The following is a description of a gene set: studied in species Homo sapiens The process that mediates signaling interactions between one cell and another cell by transfer of current between their adjacent cytoplasms via intercellular protein channels and contributes to the process of cardiac conduction. Human Gene Set: GOBP_CELL_COMMUNICATION_BY_ELECTRICAL_COUPLING_INVOLVED_IN_CARDIAC_CONDUCTION, and this is the list of marker genes: HRC, TRDN, CALM3, GJC3, ATP1B1, PKP2, CAMK2D, ATP1A3, GJD3, IRX3, GJA1, CACNA1C, ATP1B2, ATP1A2, CALM2, SRI, CALM1, CAV1, RYR2, ATP1A1, SLC8A1, PRKACA, PDE4D, TBX5, GJC1, GJA5